The following is a description of a gene set: studied in species Mus musculus Mouse Gene Set: GOBP_REGULATION_OF_SYNAPTIC_TRANSMISSION_GLUTAMATERGIC Any process that modulates the frequency, rate or extent of glutamatergic synaptic transmission, the process of communication from a neuron to another neuron across a synapse using the neurotransmitter glutamate., and this is the list of marker genes: Frrs1l, Cacng3, Ngfr, Nps, Egfr (NCBI Gene Id 13649), Ccl2, Plppr4, Cacng7, Shank2, Grm1, Nlgn3, Grik2, Grm7, Cdh2, Nlgn1, Grm4, Tshz3, Cckbr, Dkk1, Npy2r, Cacng8, Cdk5, Htr2a, Prkn, Ror2, Drd2, Grin2b, Rnf167, Ccr2, Rab3gap1 (RAB3 GTPase activating protein subunit 1), Myo5a, Glul, Nlgn2, Syt1, Grik1, Ucn, Mapk8ip2, Grik3, Cacng2, Shank3, Nrxn1, Tnr, Ntrk2, Cnr1, Atad1, Kmo, Dgki, Ptk2b, Grm8, Drd3, Dtnbp1, Iqsec2, Cacng4, Serpine2, Gria2, Adora1, Adora2a (adenosine A2a receptor), Cln3, Prkaca, Grin2c, Stxbp1, Cacng5, Grin1, Homer1, Ophn1, Reln, Drd1, Mef2c, Grm3, Pla2g6, Fxr1, Hdac6 (NCBI Gene Id 20374), Grin2a (glutamate receptor, ionotropic, NMDA2A (epsilon 1)), Oxtr, Slc38a2, Htr1b, Grm6, Grm2, Gria4, Lrrk2, Ptgs2, Adcyap1, Psen1, Grin2d, Grm5, Tprg1l, Disc1, Ntrk1